The following is a description of a gene set: studied in species Homo sapiens Genes in the cancer module 453. Human Gene Set: MODULE_453, and this is the list of marker genes: PFKM, VAV2, RAVER1, HCAR1, GNS, INTS1, FKBP3, CD109, ANXA13, PAK1IP1, NEO1, PLBD1 (phospholipase B domain containing 1), ITSN2, FAM181A, CTPS1, TUSC3, CFP, KMT2D, NSUN3, KIF14, TUBE1, IKZF4, HMBS, SHCBP1, MT1G, LDB3, BTAF1, CCNF, GPRASP1 (G protein-coupled receptor associated sorting protein 1), ITCH, MEAK7, NUDT15, ZBTB10, HCFC1, ANP32E, OSBPL10, KLHDC10, SYT4, ITIH3, SETD6, INPPL1, DHRS11, APP, TGM2